Given this list of marker genes POU3F3, LIMK2, SPRYD3, ATF2, SLC6A7, MEIS2, here is a description of the gene set: Genes having at least one occurrence of the motif AACACGGATATCTGTGGTY in the regions spanning 4 kb centered on their transcription starting sites. This matches the transcription factor binding site V$SEF1_C (v7.4 TRANSFAC). Human Gene Set: SEF1_C studied in species Homo sapiens